The following is a description of a gene set: Top 100 ranked genes most specific to the cerebellum region of adult mouse brain. Human Gene Set: LEIN_CEREBELLUM_MARKERS Molecular approaches to understanding the functional circuitry of the nervous system promise new insights into the relationship between genes, brain and behaviour. The cellular diversity of the brain necessitates a cellular resolution approach towards understanding the functional genomics of the nervous system. We describe here an anatomically comprehensive digital atlas containing the expression patterns of approximately genes in the adult mouse brain. Data were generated using automated high-throughput procedures for in situ hybridization and data acquisition, and are publicly accessible online. Newly developed image-based informatics tools allow global genome-scale structural analysis and cross-correlation, as well as identification of regionally enriched genes. Unbiased fine-resolution analysis has identified highly specific cellular markers as well as extensive evidence of cellular heterogeneity not evident in classical neuroanatomical atlases. This highly standardized atlas provides an open, primary data resource for a wide variety of further studies concerning brain organization and function. species: Mus musculus from publication Lein ES, Hawrylycz MJ, Ao N, Ayres M, Bensinger A, Bernard A, Boe AF, Boguski MS, Brockway KS, Byrnes EJ, Chen L, Chen L, Chen TM, Chin MC, Chong J, Crook BE, Czaplinska A, Dang CN, Datta S, Dee NR, Desaki AL, Desta T, Diep E, Dolbeare TA, Donelan MJ, Dong HW, Dougherty JG, Duncan BJ, Ebbert AJ, Eichele G, Estin LK, Faber C, Facer BA, Fields R, Fischer SR, Fliss TP, Frensley C, Gates SN, Glattfelder KJ, Halverson KR, Hart MR, Hohmann JG, Howell MP, Jeung DP, Johnson RA, Karr PT, Kawal R, Kidney JM, Knapik RH, Kuan CL, Lake JH, Laramee AR, Larsen KD, Lau C, Lemon TA, Liang AJ, Liu Y, Luong LT, Michaels J, Morgan JJ, Morgan RJ, Mortrud MT, Mosqueda NF, Ng LL, Ng R, Orta GJ, Overly CC, Pak TH, Parry SE, Pathak SD, Pearson OC, Puchalski RB, Riley ZL, Rockett HR, Rowland SA, Royall JJ, Ruiz MJ, Sarno NR, Schaffnit K, Shapovalova NV, Sivisay T, Slaughterbeck CR, Smith SC, Smith KA, Smith BI, Sodt AJ, Stewart NN, Stumpf KR, Sunkin SM, Sutram M, Tam A, Teemer CD, Thaller C, Thompson CL, Varnam LR, Visel A, Whitlock RM, Wohnoutka PE, Wolkey CK, Wong VY, Wood M, Yaylaoglu MB, Young RC, Youngstrom BL, Yuan XF, Zhang B, Zwingman TA, Jones AR (PMID 17151600), and this is the list of marker genes: ARHGAP5, SYNE2, CALB2, HBEGF, B3GNT5, NKAIN4, NTN1, ARAP1, TJP2, PCP2, TRIM62, ICMT, ERC1, MCC, CNKSR3, PTPRM, TNC, ZNF521, RHOD, DNAJC3, EN2, PAQR6, ARHGEF37, SLC66A2, NEK2, LHX5, CMYA5, FEZ2, KCNT1, CEP72, FBXO24, CRTAM, NHLH1, HEPACAM, RNF182, DMD, SLC9A3, KANK2, FAM107A, GPR63, GABRA6, ZNF385C, TMEM266, DHRS3, EXPH5, TMEM41A, KIT (KIT proto-oncogene, receptor tyrosine kinase), GNG13, PEPD, SELENOS, PKP3, AMOT, ETV4, H6PD, MMP24, CA7, LIG1, ZIC1, SEBOX, SYTL3, AFAP1L2, MTCL2, DMRTC2, BTG1, GDF10, NAT8, RIF1, PHKA1, IL16 (interleukin 16), COL18A1, CBLN3, TRAF6, LHX1, TST, PDP2, ZIC2, LRCH1, PREX2, PLXDC1, CASQ2, SLC25A18, GSAP, SPRY3, NPR1, CHD7